The following is a description of a gene set: Reactome Pathway: RUNX1 and FOXP3 control the development of regulatory T lymphocytes (Tregs) This event has been computationally inferred from an event that has been demonstrated in another species.<p>The inference is based on the homology mapping from PANTHER. Briefly, reactions for which all involved PhysicalEntities (in input, output and catalyst) have a mapped orthologue/paralogue (for complexes at least 75% of components must have a mapping) are inferred to the other species. electronically inferred by orthology from the curated human pathway part of: Transcriptional regulation by RUNX1 species: Mus musculus, and this is the list of marker genes: Cbfb, Foxp3